The following is a description of a gene set: Human Gene Set: HP_TIBIALIS_ANTERIOR_MUSCLE_ATROPHY Wasting of the tibialis anterior muscle. Tibialis anterior muscle atrophy species: Homo sapiens, and this is the list of marker genes: MYH7, RYR1, DYSF, TTN, MTRFR